The following is a description of a gene set: species: Homo sapiens Human Gene Set: MIR4653_5P from publication Chen Y, Wang X (PMID 31504780) Genes predicted to be targets of miRBase v22 microRNA hsa-miR-4653-5p in miRDB v6.0 with MirTarget v4 prediction scores > 80 (high confidence targets)., and this is the list of marker genes: SAR1B, HIF1A, DCUN1D5, AHCYL1, WBP1L (NCBI Gene Id 54909), SZRD1, POMGNT1, ANKRD53, ERLIN1, JPH4, MXD1, SGO1, EGR2, NUDCD3, CHST14, ERP27, ARID4A, CNTN4, ZFX, BNC2, PTPN12, PPP1R3G, C1QTNF5, CAMK1D, UBE2E3, PEA15, IRGQ, VAV3, STK4, NLRP5, SEC14L3, C1orf21, PDS5A, FMNL3, MAPK1IP1L, FOXC1, VASN, HHEX, AQP5 (aquaporin 5), HIC2, PLXNA4, TREM1, WDR48, RMI2, EIF3J, SLC44A1, ZNF398, CPS1, MARCHF6, KRTAP8-1, CALB2 (NCBI Gene Id 794), DHCR24, TACR2, SH3PXD2A, CERCAM, LYRM9, P2RX7, TNFRSF10D, TRABD2A, KAT6A, SLC24A4, TMEM116, SDF2, SSBP4, ZNF322, DSCAML1, PLPPR4, SLC35C2, WDFY2, NYAP2, NLRP2B, STARD5, PIAS1, UMODL1, TMEM241, EPHB2, PPP2R3A, LIPT2, DEFB132, BMP2, SLC16A8, CYP8B1, CD4, WIPF3, GABRR2, ST8SIA5, TMEM144, RORC, TBC1D5, TNFAIP3, CMTR1, HOMER1, HYCC2, MFRP, MLLT11, MBD6, RNF222 (ring finger protein 222), ANKFY1 (ankyrin repeat and FYVE domain containing 1), CEMIP, FOXJ2, KCNJ12, TMEM120B, PLEKHG4, ZEB1, NPAS3 (neuronal PAS domain protein 3), TXNIP, AMN1, NUBP1, CNOT9, SGCB, MTX3 (NCBI Gene Id 345778), ZBED4, APIP, CFAP65, NCOA7, SET, RIPK1, ZFYVE26, RASSF6 (Ras association domain family member 6), G6PC2, HES5, TTC17, ZSCAN12, CEACAM6, ZNF544 (NCBI Gene Id 27300), RPE65, PPP4R1, ZDHHC21, RUBCN, LVRN, ZNF12, LRRC3, TSHZ1, ZNF248, FAM124A, OSBPL3, UPF1, KCNIP1, ASXL3, KCNQ3 (NCBI Gene Id 3786), JMJD8 (NCBI Gene Id 64483), ARID2 (AT-rich interaction domain 2), CCM2, MEA1, SLC14A1, SEMA3G, TMEM154, KLF12